Given this list of marker genes ARL8A, HIF1A, RAB17, AP3B1, FEZ1 (NCBI Gene Id 9638), NEFL, KIF5C, DST, STAU2, BORCS5, SPG11 (SPG11 vesicle trafficking associated, spatacsin), KIFAP3, SPG7, HNRNPU, TERF2, HSBP1, ARL8B, KIF1C, DTNBP1, MAPT, KIF1A, ATG5, KIF5A, RAB21, MAP2, DLG2, OPA1, SFPQ, AGTPBP1, TRIM46, AP3B2, MGARP, BLOC1S4, WASF1, FBXW11, DYNC1H1, AP3M2, SNAPIN, TRAK1, BLOC1S1, DCTN1 (dynactin subunit 1), KIF3A, STAU1, MAPK8IP3, RAB27B, RUFY4, KIF4A, SOD1, TMEM108, FLOT2, HSPB1, KIF5B, AP3S2, TMEM230, KIF3B, ARMCX3, ATG16L1, BLOC1S5, NDEL1, HAP1, SYBU, BLOC1S2, HDAC6, MAP1A, KIF1B, AP3M1, RUFY3, RABGEF1, APBA1, APP, PURA, SPAST, TRAK2, ACTR10, BLOC1S6, AGBL4, UCHL1, KIF21A, KIF17, PAFAH1B1, BLOC1S3, AP3D1, NETO1, KIFC2, AP3S1, KLC3, here is a description of the gene set: species: Homo sapiens The directed movement of organelles or molecules along microtubules in neuron projections. Human Gene Set: GOBP_AXO_DENDRITIC_TRANSPORT